Given this list of marker genes Ctsh (cathepsin H), Ctsb, Brd8, Inhbb, Rdx, Gclm, Med1, Gclc, Gh, Ghsr, Ppargc1a, Thrb, here is a description of the gene set: studied in species Mus musculus A change in state or activity of a cell (in terms of movement, secretion, enzyme production, gene expression, etc.) as a result of a thyroid hormone stimulus. Mouse Gene Set: GOBP_CELLULAR_RESPONSE_TO_THYROID_HORMONE_STIMULUS